The following is a description of a gene set: studied in species Mus musculus Mouse Gene Set: CUI_CDC2_IFNB_RESPONSE_DN Cytokines mediate cell-cell communication in the immune system and represent important therapeutic targets. A myriad of studies have highlighted their central role in immune function, yet we lack a global view of the cellular responses of each immune cell type to each cytokine. To address this gap, the authors created the Immune Dictionary, a compendium of single-cell transcriptomic profiles of more than 17 immune cell types in response to each of 86 cytokines (>1,400 cytokine-cell type combinations) in mouse lymph nodes in vivo. A cytokine-centric view of the dictionary revealed that most cytokines induce highly cell-type-specific responses. For example, the inflammatory cytokine interleukin-1β induces distinct gene programmes in almost every cell type. A cell-type-centric view of the dictionary identified more than 66 cytokine-driven cellular polarization states across immune cell types, including previously uncharacterized states such as an interleukin-18-induced polyfunctional natural killer cell state. from publication Cui A, Huang T, Li S, Ma A, Pérez JL, Sander C, Keskin DB, Wu CJ, Fraenkel E, Hacohen N (PMID 38057668) Genes negatively differentially expressed in cell type: cDC2 (conventional dendritic cell type 2) upon treatment with cytokine: IFN-β in mouse lymph nodes in vivo., and this is the list of marker genes: Pabpc1, Pgap1, Rnf130, Eef2, Maf1, B4galt6, Pi16, Elovl5, Il6ra, Atp5pd, Myh9, Mink1, Fos, Fth1, Cd200r1, Tyrobp, Rnd3, Slc12a6, Rgs18, Ctsh, Akap8l, Ramp1, Supt16, H2-Ab1, Alox5ap, Fosb, Dusp1, Sfxn3 (sideroflexin 3), Mt1, L1cam, Zfp36l1, Mcemp1, H2az1, Hnrnpa1, Slc4a7, Slc43a2, Mapk14, Cd300ld, Susd3, Creg1, Usf2 (NCBI Gene Id 22282), Septin6, Emp3, Tmem109, Fuca1, Cd209e, Nsa2, Rp9 (retinitis pigmentosa 9 (human)), H2-DMb1, Gpx4, Prkar2a, Mknk2, Smc3, Lage3, Eif3e (eukaryotic translation initiation factor 3, subunit E), Slc48a1, Ccr2 (C-C motif chemokine receptor 2), Bin1, Eid1, Gpi1, Arhgap9, Irak1, Pmaip1, Cd9, Prdx6, Abhd17a, Nop10, Zdhhc20, Cd209a, Aph1c, Tacc1, Trappc5, Stap1, Hfe, Bri3bp, Eef1d, Klrd1, Trmt112, Clec4b1, Eif3k, St8sia4, Ncl, Stard9, Irag2, Gfra2, Gdi2, Ypel3, Pnisr, Tmem176b, Arhgef6, D8Ertd738e, Laptm5, Naa38, Wdfy2, Nap1l1, Ssh2, Gpx1, Macf1, Snx29, Trps1, Tm2d2, Emc6, Gpsm3, Ppp1r21, Hnrnpr, Eif3f, Xist, Cd48, Eef1a1, Ebpl, Arhgdib, Syngr2, Stk10, Trim28, Pcbp2, Bmyc, Zfp36l2, Fam234b, Mrpl52, Cd209d, Parp1, Gltp, Cox7a2l, Kctd12, Tnfaip8, Deptor, Man2b1, Eif3a, Pbxip1, Atp5mc2, Akap13, Specc1, Klf4, Erp29, Tubb5, Alcam, Rnf150, Imp3, Ndufa6 (NADH:ubiquinone oxidoreductase subunit A6), Il6st, Naca, Exosc5, Dna2, Fau, Bmp2k, Dab2 (disabled 2, mitogen-responsive phosphoprotein), Dhrs7, Ckap4, Bnip3l, Plbd1, Guk1, Clec4a2, H1f2, Emb, Ptp4a3, Fcgrt, Fcor, Fcgr2b, Klhl24, Herc1 (HECT and RLD domain containing E3 ubiquitin protein ligase family member 1), Flt3, Mtdh, Abhd4, Ttc3, Hnrnpu, Pid1, Sh3bgrl3 (SH3 domain binding glutamic acid-rich protein-like 3), Septin3, Camk1d, Gm2a, Irf4, Foxp1, Asnsd1, Polr2e, Slc38a1, Cyp4f16, Ucp2, Higd2a, Scd2, Marveld1, Emsy, Apbb1ip, Matk, Pdcd4, Polr1d, Cbr3, Fam168a, Ifngr1, Mrpl12, Tbl1xr1, Gnpda1, Syk, Coro1a, R3hdm1 (NCBI Gene Id 226412), Usp48, Mxd4, Btg2, Ier2, Pgls, Ndufb8, Dnajb14, Tm9sf3, Tmcc1, Tsc22d3, Cd33, Gpr68, Anp32b, Ankrd44, Csf1r, Rnf13, Cx3cr1, H2-Aa, Ppp1r14b, Ptpn12, Asap1, Agpat4, Cbl, Eef1b2, Ear2, Colgalt1, Sirpa, Rack1, Ctnna1, Lpin1, Mrc1, Shtn1, Hmgb1, Daglb, Tnfrsf13b, H2-DMa, Chd4, Pan3, Prcp, Lipa, Cd37, Lmo4, Eif4ebp2, Cd244a, Pold4, Fbl (fibrillarin), Niban1, Septin9 (septin 9), Ccdc88a, Eef1g, Fermt3, Mbtps1, Atp5mg, Npm1, Nfam1